The following is a description of a gene set: Mouse Gene Set: MIR_7237_5P studied in species Mus musculus Genes predicted to be targets of miRBase v22 microRNA mmu_miR_7237_5p in miRDB v6.0 with MirTarget v4 prediction scores > 80 (high confidence targets). from publication Chen Y, Wang X (PMID 31504780), and this is the list of marker genes: Meox2, Clca4a, Cpa6, Tlr9, Gtsf1, Col4a2, Sav1, Glrp1, Tmem132c, Styx, Grp, Podn, Sprn, Odad2, Usp46, Serpinb8, Cul4a, Slc39a9, Klhl36, Trps1, Scd4, Col25a1, Prpf39, Klrb1b, Setbp1, Iqck, Sprr1a, Mro, Mrpl17, Arhgap6, Spg21, Fbxo11, Ifi35, Pou2f1, Srsf6, Rab9b, Tnfrsf26, Pgm5, AI593442, Pcnp, Bcl2, Gad2, Krtap4-1, Ano1, Ssx2ip, Naa30, Esr1